The following is a description of a gene set: species: Homo sapiens Decreased body mass index Human Gene Set: HP_DECREASED_BODY_MASS_INDEX Abnormally decreased weight-to-height squared ratio, calculated by dividing the individual's weight in kilograms by the square of the individual's height in meters and used as an indicator of underweight compared to averages., and this is the list of marker genes: KCNN4, SLC25A13, TNFRSF11B, MIF, ANKH, HTT (huntingtin), SLC16A2, CEACAM6, SLC26A9, EDNRA, SLC6A14, SERPINA1, SLC11A1, DCTN4, STX1A, TGFB1, SLC9A3, SLC2A3, HFE, GCLC, GSTM3, CEACAM3, CFTR, HMOX1, CLCA4